Given this list of marker genes STAT3, IRF1, CD40LG, RNF31, C1QB, CARD9, IL17RC, TLR8, ZAP70, IL21R, CARD11, PSMB10, IL12RB1, IKBKG, PDCD1, TGFB1, IL2RG, ZBTB24, PIK3CD, STAT1, here is a description of the gene set: An infection that is caused by a fungus that would generally not be able to cause an infection in a host with a normal immune system. Such fungi take advantage of the opportunity, so to speak, that is provided by a weakened immune system. Human Gene Set: HP_OPPORTUNISTIC_FUNGAL_INFECTION Opportunistic fungal infection species: Homo sapiens